Given this list of marker genes ANAPC11, ANAPC2 (NCBI Gene Id 29882), ANAPC4, CDK1, ANAPC10, UBE2S, CDC16, UBE2C, ANAPC15, ANAPC1, ANAPC16, ANAPC7 (NCBI Gene Id 51434), UBE2E1, CCNB1, UBE2D1, CDC26, CDC23, PLK1, CDC27, ANAPC5, here is a description of the gene set: Human Gene Set: REACTOME_PHOSPHORYLATION_OF_THE_APC_C Phosphorylation of the APC/C studied in species Homo sapiens